The following is a description of a gene set: The addition of a sulfate group as an ester to a protein amino acid. species: Mus musculus Mouse Gene Set: GOBP_PROTEIN_SULFATION, and this is the list of marker genes: Slc35b2, Tpst1, Chst4, Hs3st5, Slc35b3, Hs3st3b1, Tpst2, Ndst1